Given this list of marker genes GTF3C3 (general transcription factor IIIC subunit 3), TAF11L13, GTF3C4, TAF11L10, TAF12, GTF2B, UBTFL6, GTF2F1, GTF3C2, TAF11L7, GTF3C5, GTF2E2, PAAF1, TAF5, CCNH, GTF2A1, RRN3P2, TAF9, TAF2, TAF11L12, DR1, TBPL1, SNAPC1, TAF13, TAF4B, GTF3C1, BRF2, SNAPC2, GTF2A2, GTF2F2, TBP, TAF11L2, TAF8, SNAPC4, TBPL2, TAF11L4, TAF10 (NCBI Gene Id 6881), GTF2E1, TAF4, TAF11L8, RRN3P1, UBTF, TAF11L14, TAF11L9, TAF1, BRF1 (NCBI Gene Id 90137), DRAP1, GTF2H4, TAF1C, TAF6, UBTFL1 (upstream binding transcription factor like 1), SNAPC3, SNAPC5, GTF2H2, TAF11, TAF11L6, TAF1L, TAF11L3, TAF11L11, TAF7L, TAF3, TAF7, GTF3C6, TAF6L (TATA-box binding protein associated factor 6 like), GTF2H3, RRN3, TAF9B (TATA-box binding protein associated factor 9b), PRRX1, here is a description of the gene set: A molecular function required for core promoter activity that mediates the assembly of the RNA polymerase holoenzyme at promoter DNA to form the pre-initiation complex (PIC). General transcription factors (GTFs) bind to and open promoter DNA, initiate RNA synthesis and stimulate the escape of the polymerase from the promoter. Not all subunits of the general transcription factor are necessarily present at all promoters to initiate transcription. GTFs act at each promoter, although the exact subunit composition at individual promoters may vary. species: Homo sapiens Human Gene Set: GOMF_GENERAL_TRANSCRIPTION_INITIATION_FACTOR_ACTIVITY